The following is a description of a gene set: The process in which a relatively unspecialized cell acquires specialized features of a neural crest cell. species: Mus musculus Mouse Gene Set: GOBP_NEURAL_CREST_CELL_DIFFERENTIATION, and this is the list of marker genes: Sema5a, Snai2, Foxc1, Shh, Sema3c, Sox9, Erbb4, Bmp7, Sema3e, Pax3, Tfap2a, Cyp26a1, Pdcd6, Zic2, Nrtn, Edn1, Ovol2, Acvr1, Sema4b, Otud5, Ret (NCBI Gene Id 19713), Eng, Hes1, Zic5, Ext1, Phox2b, Lrp6, Sema4d, Ednra, Rps7, Mapk1, Smad4, Sema4f, Sema4a (NCBI Gene Id 99554), Pax6, Pef1, Nolc1, Mef2c, Smo, Phactr4, Sema3g, Bmp4, Efnb1, Tcof1, Cyp26c1, Twist1, Sox8, Sema6c, Jag1 (NCBI Gene Id 170642), Sema3b, Edn3, Hand2, Wnt10a, Sema6d, Sema6b, Klhl12, Sema4g, Ankrd11, Pitx2, Sema7a, Folr1 (folate receptor alpha), Zeb2, Gbx2, Sema4c, Radil, Lama5 (laminin, alpha 5), Mapk3, Fn1, Fbxl17, Rdh10, Hif1a, Arb2a, Cdh2, Tapt1, Foxc2, Bmpr1a, Aldh1a2 (aldehyde dehydrogenase family 1, subfamily A2), Sfrp1, Nrp1, Frzb, Kbtbd8, Cdc42, Sox10, Sema3a, Cited2, Nrp2 (NCBI Gene Id 68752, neuropilin 2), Coro1c, Sema6a, Sema3d, Isl1, Mir452, Dicer1, Cfl1, Sema5b, Fgf15, Htr2b, Ednrb, Gdnf, Gsc, Kitl, Sema3f, Tbx1, Six1